The following is a description of a gene set: The aggregation, arrangement and bonding together of a set of components to form a nuclear pore complex. Mouse Gene Set: GOBP_NUCLEAR_PORE_COMPLEX_ASSEMBLY studied in species Mus musculus, and this is the list of marker genes: Ahctf1, Tpr, Tmem170, Nup93, Nup107, Nup205, Fxr1, Nup98, Ndc1, Nup153, Rtn4